Given this list of marker genes TFAP2B (transcription factor AP-2 beta), BMPR1B, PCNT, SF3B4, NOG (NCBI Gene Id 9241), UBAP2L, GDF5, IHH, here is a description of the gene set: Distal symphalangism Human Gene Set: HP_DISTAL_SYMPHALANGISM species: Homo sapiens